Given this list of marker genes IGSF6, EFHD2, SLCO2B1, MSR1, RILPL2, CYRIA, ARRB2, CHCHD10, PLEKHO1, MOB1A, RNF213 (NCBI Gene Id 79398), SGK1, FMNL1, TTYH3, ADAM9 (ADAM metallopeptidase domain 9), CLEC7A, ASAH1, TANK, PLIN2, NFKBIE, ITGAX, GATM, GPR137B, REL, FOLR2, FOSL2, HLA-DPA1, IL10RA, ZNF331, ATP6V1H, SIRPA, GPNMB, PLAU, ATP6V1C1, CYRIB, ANPEP, LPAR6, ATP6V0D1, RNASE6, ALOX5AP, RNASET2, AP1B1, HCLS1, GAPLINC, RNF149, CSTA, TNF, RNASE1, GNA13, G0S2, TNFAIP2, DAZAP2, PLEK, CCL2 (NCBI Gene Id 6347), NRP1, ARID5A, ACP5, CCL20, RASSF4, FNIP2, NFKBIA, PFKFB3, DSE, HSD17B11, CD74 (CD74 molecule), KLF6, CYTIP, CAP1, WAS, TAOK3, SAMSN1, BID, RASGEF1B, FERMT3, PTPN1, SDCBP, VSIG4, VMO1, HLA-DMA, MXD1 (MAX dimerization protein 1), PTPRE, BIRC3, RAP1A, RNF144B, LILRB4, RAP2B, CD83, RAC2, SLC16A10, GK, TNFRSF14, MS4A4A, COTL1, ETS2, PHACTR1, MPP1, AKR1B1 (aldo-keto reductase family 1 member B), OGFRL1, CCL4, RHOG, IQGAP2, CXCL8, CD37, GNS, MIR155HG, TREM2 (NCBI Gene Id 54209), LY86, IRF8, RB1, PPP1R18, FRMD4B, CCL4L2, CSF1R, M6PR, HPGDS, CHMP1B, VAT1, CSF2RA, MBP, ELF1, C15orf48, VAMP8, FGL2, RGS1, RALGDS, TAGAP, STAB1, PLXND1 (NCBI Gene Id 23652), HLA-DPB1, TYROBP, HLA-DQA2, GLRX, C1orf162, MGAT4A, HLA-DRB1 (NCBI Gene Id 730415), DUSP6, CD68, SLC11A1, CCL3, S100A9, CXCL16, KYNU, LST1, CORO1C (coronin 1C), QKI, C1QC, SPI1, CXCL1, RBM47, IL1RN, MMP9, CPEB4, GRB2, STK4, FCGR3A, TNFSF13B, RAB5C, C1QA, LIPA, CASP1, LYZ, KDM6B, CD14, CXCL2, PPIF, CD86, TNFRSF1B, GPR183, PCBD1, OSTF1, CTSH, CTSZ, C1orf54, RGS10, HLA-DQA1, STK17B, RALA, TNFAIP8, ZNF267, CD163, GLIPR1, CORO1A, PTPRC, LCP1, APOE, PTPN6, COMMD9, CXCL3, NFKB1, SLC43A3, MYO9B, GMFG, PTGER4, TUBGCP2, USP12, NLRP3 (NCBI Gene Id 9558), MS4A7, SMIM30, BCL2A1, HAVCR2, HK2, CLEC2B, CFLAR, HLA-DRA, CD4, EVI2B, ARL4A, CMTM6, LY96, SNX10, RNF130, CALHM6, THBD, UCP2 (NCBI Gene Id 7351), CSGALNACT2, NCF2, CD48, IL1B, CTSB, FYB1, CD93, FNBP1 (formin binding protein 1), MGAT1, SMAP2, LYN, FOXN3, CD84, FCER1G, SNX9, CD300A, RASGRP3, CREM, ARHGAP18, CNPY3, NCF4, CELF2, APOC1, BAZ1A, SQOR, ABCA1, RAPGEF1, WIPF1, ZNF385A, FCGR1A, IL18, DAB2, STX7, LAIR1, AMPD3, SYNGR2, PRDM1, METRNL, PILRA, FAM107B, MFSD1, HBEGF, FCGR2B, SEC14L1, FCGRT, MAP3K8, FCGR2A, CARD16, TPP1, THEMIS2, ADAM8, SRGN, C1QB, ZEB2, OTUD1, STX11, CTSS, LHFPL2, LGALS9, ABRACL, LACTB, CLN8, PDE4B, DOK2, ENG, CCL5, LCP2 (lymphocyte cytosolic protein 2), CITED2, CD53, NPL, TMEM176B, HLA-DQB1, ADAP2, AIF1, ATP13A3, OTOA, MS4A6A, C5AR1, KCTD12, CNDP2, GPSM3 (G protein signaling modulator 3), FPR3, CD44, CAPZA1, RGS19, GNAQ, CREG1, HNMT, TREM1, SNX2, CXCR4, AP1S2, RAB20, RIPK2 (NCBI Gene Id 8767), NCOA4, HLA-DMB, TNFAIP3 (TNF alpha induced protein 3), ACSL1, SERPINB9, ARHGDIB, HCST, here is a description of the gene set: species: Homo sapiens from publication Su Z, Ho JWK, Yau RCH, Lam YL, Shek TWH, Yeung MCF, Chen H, Oreffo ROC, Cheah KSE, Cheung KSC (PMID 38267611) The transformation of benign lesions to malignant tumours is a crucial aspect of understanding chondrosarcomas, which are malignant cartilage tumours that could develop from benign chondroid lesions. However, the process of malignant transformation for chondroid lesions remains poorly understood, and no reliable markers are available to aid clinical decision-making. To address this issue, we conducted a study analysing 11 primary cartilage tumours and controls using single-cell RNA sequencing. By creating a single-cell atlas, we were able to identify the role of endoplasmic reticulum (ER) stress in the malignant transformation of conventional central chondrosarcomas (CCCS). Our research revealed that lower levels of ER stress promote chondrosarcoma growth in a patient-derived xenograft mouse model, while intensive ER stress reduces primary chondrosarcoma cell viability. Furthermore, we discovered that the NF-?B pathway alleviates ER stress-induced apoptosis during chondrosarcoma progression. Our single-cell signatures and large public data support the use of key ER stress regulators, such as DNA Damage Inducible Transcript 3 (DDIT3; also known as CHOP), as malignant markers for overall patient survival. Ultimately, our study highlights the significant role that ER stress plays in the malignant transformation of cartilaginous tumours and provides a valuable resource for future diagnostic markers and therapeutic strategies. Human Gene Set: SU_HO_CONV_CENT_CHONDROSARCOMA_C6_LEUKOCYTE A heterogeneous cell population characterized by both myeloid (e.g., CD68, CD74) and lymphocyte (e.g., LY96) lineage markers.